The following is a description of a gene set: species: Homo sapiens Human Gene Set: GOBP_FOREBRAIN_DEVELOPMENT The process whose specific outcome is the progression of the forebrain over time, from its formation to the mature structure. The forebrain is the anterior of the three primary divisions of the developing chordate brain or the corresponding part of the adult brain (in vertebrates, includes especially the cerebral hemispheres, the thalamus, and the hypothalamus and especially in higher vertebrates is the main control center for sensory and associative information processing, visceral functions, and voluntary motor functions)., and this is the list of marker genes: PLXNA4, EXT1 (NCBI Gene Id 3966), SEMA7A, PSEN1, NOTCH2NLC (notch 2 N-terminal like C), WNT2B, WDR62, GHRHR, TFAP2C, TTBK2, POU1F1, EIF2B5, ROBO2, WDR47, CCKAR, CSF1R (NCBI Gene Id 8156), UNCX, PAX5, FILIP1, RRM1 (NCBI Gene Id 6240), TRAPPC9, NR2F2, DLC1, PLCB1, VPS13B, HIF1A, IGF2BP1, PITX1, YWHAE, EFHC1, FGF13 (NCBI Gene Id 730528), DIXDC1, NSUN5, NEFL, HESX1, RTN4, CEP120, BMP4, MCPH1 (microcephalin 1), ZEB2, LMX1A, PRKG1, PGAP1, TCTN1, GSK3B, SRD5A1, KCNA2, ATRX, BTBD3, UBB, SLC6A3, SCYL2, ASCL1, STIL, WNT1, NKX2-6, FBXO41, CCDC39, TAL2, CHD7, SLC38A2, DISC1, NHLH2, TWSG1, FRS2, AGTPBP1 (ATP/GTP binding carboxypeptidase 1), BBS1, RARB, DNAH5, ITGAM, COL3A1, DCLK2, TSC1, RPGRIP1L, AVPR2, FOXG1, BCAN (NCBI Gene Id 84774), FXR1, TNR, MSX1 (NCBI Gene Id 4487), GSC, NF2, DLX2, SLC2A1, EZH2, DCT, UCHL5 (ubiquitin C-terminal hydrolase L5), CNTNAP2, NEUROG3, GBX2, ASPM, KDM1A, WDR37, MKKS, EFNA2, POMT2, RAN, CRTAC1, SALL1, XRCC1, AQP1, KIRREL3, KIF14, ID2, TBX3, AKNA, PCDH9, PTEN, SRD5A2, PEX13, CNTN2, SLC4A10 (NCBI Gene Id 57282), LHX3, PAX6, NOG (NCBI Gene Id 9241), HOOK3, ZIC1, RBPJ, KDM2B, EGFR, SOX3, ATAT1, PTCHD1, KCNC2, WNT5A, APAF1 (NCBI Gene Id 317), DRD2, HDAC1, EPHB2, PIANP, HES5, OTX2, EMX2, FGFR2 (NCBI Gene Id 2263), RAC1, PCM1, FXR2, EOMES, SIX3, SYNE2, RAX, CHRNB2, KCNC1, EPHA5, DPCD, FOXP2, CRKL, OTP (orthopedia homeobox), PEX5, FOXB1, WNT4, NDNF, RTN4RL2, B2M, PROX1, PROP1, FYN, FUT1, RTN4R, CDK5, ATP1A2, CDK5R2, OLIG2, XAB2, DMRTA2 (NCBI Gene Id 63950), CDK5R1, SLIT2, ARX, OPHN1, CDH1, POU3F2, SLC1A2, TUBB2A, GDF7, PHLPP2, TSKU, TOX, EZH1, GMPPA, NR4A3, NUMB, KIAA0319, RAC3, FGF2, ATOH1, AKIRIN2, FEZF1, SUN1, NDST1, POMGNT1, NOTCH1, RAPGEF2, ATF5, APLP1, DNAJB1, TMEM14B, SEMA6B, MFSD2A, CFL1, CCDC85C, FLNA, TTC21B, PITX2, TBR1, BMP2, BLOC1S6, ID4, BBS2, HTR5A, CDK6, FGF8, SOX2, CTNNB1, FEZF2, SECISBP2, NRG3, DYNC2H1, TUBA1A, BBS4, NUMBL, FKTN, NKX2-1, NF1, ZSWIM6, OGDH, MDGA1, SLC7A11, TUBB2B, ARHGAP11B, UQCRQ, ZMIZ1, LPAR1, LRP8, PPP1R9B, SUN2, NEUROD1 (NCBI Gene Id 7853), RFX4, BMPR1A, TYRO3, BNIP3, EPHB3, EMX1, SEMA3A, DOCK7, DLX5, ATG16L1, GRIA1, LRP2, ATP2B4, ATP1B2, ZDHHC16, PLXNA1, CDH2, ARL13B, SRF, TYROBP, GART, AVPR1A, NOTCH3, NDE1, DLX1, SLIT1, SLIT3, AXL, NRP2, NARS1, HERC1, PAFAH1B1, CRH, GLI3, HTR6, PALS1, SKI, TACC3, FGF10, MDK, MYH10, TRA2B, PRDM13, RHOA, HTRA2, FEZ1, SZT2, SCN5A, HES1, WNT7B, SSTR1, RTN4RL1, ATIC, SRC, P2RY12, CREB1, LHX6, HPRT1 (hypoxanthine phosphoribosyltransferase 1), PTPRS, FUT10, LHX5, FOXP1, BAX, VAX2, TP73, C12orf57, BMERB1, POU3F3, HMGA2, CXCL12, SLC8A3, DKK1, DAB2IP, NRGN, ATP7A, ALK, CCDC141, MBOAT7, FBXO45, BTG2, NFIB, HAP1, SRGAP2, C21orf91, SOX1, NCOA1, KDM6B, TOP2B, NR4A2, ALDH1A2, TACC2, SEMA5A, NEUROD6, CDON, PRDM8, NPY, POU3F1, XRN2, ARHGAP35, KIF26A (NCBI Gene Id 26153), SIN3A, TMEM108, CHD5, ERBB4, ALDH1A3, KCNA1, LAMB1, POU4F1, SMO, TBX19, LEF1, MGARP, WNT3A, SEMA3E, RYK, ROBO1, GSX2 (NCBI Gene Id 170825), GLI1, PLXNA3, LRRK2, NEUROG1, PHACTR1, WNT7A, GLI2, METTL14, KAT2A, KRAS, NOTCH2NLA, SOCS7, CSNK2A2, TACC1, LARGE1, GSX1, FOS, NEUROG2, ZNF335, SLC32A1, FAT4, FGFR1, BCL11B (NCBI Gene Id 64919), NR0B1, E2F1, NTRK2, NIN, ADGRG1, NR2E1, GATA2, GHRH, WDR89, CRK, METTL3 (methyltransferase 3, N6-adenosine-methyltransferase complex catalytic subunit), LHX2, ELAVL4, SCT (secretin), CASP3, DRD1, LHX8, RELN (reelin), RAB3GAP1, OTX1 (orthodenticle homeobox 1), SHH, SHANK3, ZIC3, ISL1, LHX1, DAB1, INHBA, SLITRK5, DRAXIN, CORO1C, RARA, NDEL1, SRGAP2C, NOTCH2NLB, PAX4, INHBB, TTC8, NRP1